Given this list of marker genes C2cd2l, Pth2r, Lepr, Cmklr1, Prlhr, Ednrb, Mc4r, Prlr, Oxtr, Sctr, Npr2, Insr, Vipr1, Igf1r, Gcgr, Calcr, Inhba, Glp1r, Ide, Lhcgr, Ghr, Crhr1, Glp2r, Pik3r1, Ghsr, Ramp1, Galr1, Hcrtr1, Galr3, Fshr, Cmklr2, Npr1, Ghrhr, Ramp2, Cckbr, Cckar, Vipr2, Anxa5, Il23r, Pth1r, Slc40a1, Avpr1a, Adcyap1r1, Crhbp, Hcrtr2, Mc3r, Rxfp2, Calcrl, Crhr2, Galr2, Gipr (gastric inhibitory polypeptide receptor), Npr3, here is a description of the gene set: Binding to a peptide with hormonal activity in animals. Mouse Gene Set: GOMF_PEPTIDE_HORMONE_BINDING studied in species Mus musculus